Given this list of marker genes CLCNKB, KCNJ1, SLC12A1 (NCBI Gene Id 6557), MAGED2, SLC26A3, CLCNKA, BSND, here is a description of the gene set: Human Gene Set: HP_HYPOCHLOREMIA studied in species Homo sapiens Hypochloremia An abnormally decreased chloride concentration in the blood.